The following is a description of a gene set: studied in species Homo sapiens Human Gene Set: WP_MIRNAS_INVOLVED_IN_DNA_DAMAGE_RESPONSE miRNAs involved in DNA damage response, and this is the list of marker genes: MIRLET7B, MIR374B, MIR449A, MIR34C, CCND1, MIR222, MIR210, MIR34B, MIR497, MIR15A, MIR23A, CREB1, MIR21, MIR17, E2F1, MIR424, MIR3074, MIR16-1, MIR450B, CDK6, MIR106B, H2AX, MIR100, MIR23B (NCBI Gene Id 407011), MIR195, CDC25A, MIR29A, MIR27A, MIR330, MIR372, MIRLET7D, MIR450A2, MIR421, MIR449C (microRNA 449c), MIR19A, MIR29B1, MIR373, MIR15B, MIR29C, MIR203A, MIR371A, MIR221, MIR92A1, MIR18A, MIR145 (microRNA 145), MIR503, MYC, MIR27B, MIR449B, CCND3, MIR181B1, MIR20A, MIRLET7F1, MIR25, MIR19B1, MIR181A1, MIR143, CDKN1A, ABL1, MIR542, CDKN1B, MIRLET7A1 (microRNA let-7a-1), RAD52, MIR93, MIR223, ATM, CCNE1, TP53